The following is a description of a gene set: Protuberant abdomen A thrusting or bulging out of the abdomen. Human Gene Set: HP_PROTUBERANT_ABDOMEN studied in species Homo sapiens, and this is the list of marker genes: TXNDC15, DYM, SLC26A2, LIPA, GNPTAB, SLC35D1, SMPD1, INPPL1, DLL3, GNPNAT1, KIAA0753, GNE, MTOR, DICER1, DUX4, COL2A1, MESP2, CYP27B1, PTH1R, PSAT1, FLNB, FBN1, GBA1, SMARCAL1, RTL1, FGFR3, GUSB, DNMT3B, IFT122, COL11A2, TRIP11, DUX4L1, KAT6A (NCBI Gene Id 7994), SLC37A4, FRG1, NKX3-2, SMCHD1, IDUA, MEG3, IFT52, CYP2R1, DLK1, G6PC1, LBR, PSMB8, COL11A1 (NCBI Gene Id 317718), BMPER, VDR